Given this list of marker genes TEX19, PIWIL3, CNOT7, PIWIL2, PIWIL4, HNRNPU, PIWIL1, here is a description of the gene set: Human Gene Set: GOMF_PIRNA_BINDING Binding to a piRNA, a Piwi-associated RNA, a 24- to 30-nucleotide RNA derived from repeat or complex DNA sequence elements and processed by a Dicer-independent mechanism. studied in species Homo sapiens